The following is a description of a gene set: Human Gene Set: HP_BABINSKI_SIGN Babinski sign species: Homo sapiens Upturning of the big toe (and sometimes fanning of the other toes) in response to stimulation of the sole of the foot. If the Babinski sign is present it can indicate damage to the corticospinal tract., and this is the list of marker genes: CTDP1, PEX16, PRPH, SPTAN1, PSEN1, SDHB, SDHD, UNC13A, DARS2, BICD2, AP4M1, PLP1, POLR1A, DLAT, TSEN15, SYNE1, ABCB7, CYP27A1, MAG, C19orf12, SETX, PON1, ADAR, TPP1, PTRHD1 (NCBI Gene Id 391356), SLC44A1, UFC1 (NCBI Gene Id 51506), ERLIN2, TSEN34, NDUFS4, SPAST, PYCR2, CYP7B1, DSTYK, HNRNPA1, NDE1, MATR3, HADHB, ATP2B3, ZFR, ATXN2, ANO10, WASHC5, ARSA, HMBS (hydroxymethylbilane synthase), SPG7, CAMSAP1, CACNA1G, NUBPL, OPA1, CHCHD10, NT5C2, GPT2, CFAP410, BRAT1, RARS1, CAV1, VAMP1, FGF13, RNF170, SLC39A14, DEGS1, MDH2, ATXN3, SEPSECS, PIK3R5, SLC25A46, RFC1, MPZ, SAMD9L, PRPS1, KLC2, ETHE1, PRSS12, ITPR1, VAPB, NEK1, SOD1, SQSTM1, SLC9A7, HTT, AP4B1, FA2H, SLC16A2, MTRFR, TBC1D20 (NCBI Gene Id 170488), MORC2, GAN, COQ2, SLC33A1, POLR3A, PARS2, MFN2, UCHL1, POLR3B, MTTP, SACS, MT-TE, TIMM8A, GALC, AARS1, RUSC2, PCYT2, GRIA3, KIF5A, MCOLN1, DKK1, VPS13D, BSCL2 (NCBI Gene Id 84753), ATP6AP2, PMP22, AFG3L2, AP4S1, CHMP2B, TARDBP, KIF1C, PIGA, RNASEH1, ANG, ATXN1, SNX14, TSPOAP1, JAM2, DPM3, TSEN2, CAPN1, TREM2, PRKN, DTYMK, IBA57, COQ7, AP4E1, PDYN, TSEN54, CLDN11, IMPDH2, VRK1, KPNA3 (karyopherin subunit alpha 3), KIF1A, ATL1 (NCBI Gene Id 6681), SPART, UBAP1, ATP13A2, PRNP, SHMT2, ADPRS, FARS2, NFU1, PRICKLE1, ADGRG1, HYCC1, APOE, HSPD1, CACNA1A, SLC2A3 (NCBI Gene Id 94827), CNTNAP1, UBQLN2, EIF2S3, DDHD2, TYROBP, SPG21, NDUFA4, ZFHX3, TGM6, PFN1, DDC, RETREG1, SPG11, LYRM7, HPDL, GLT8D1, TMEM63A, MECP2, PLAA, NR4A2 (NCBI Gene Id 4929), SIGMAR1, KCNA1, GFM2, NUP54, LRP12, EEF2, ATP7A, CCT5, UGDH (UDP-glucose 6-dehydrogenase), PET117, FUS, MT-ATP6, MTPAP, PPARGC1A, TFG, GCH1, COX20, REEP1, GBA2, PI4KA (NCBI Gene Id 5297), ALDH18A1, EIF2AK2, KY, ERBB4, NFASC, LETM1, TANGO2, NUP62, PNPLA6, EARS2, DARS1 (aspartyl-tRNA synthetase 1), DAO, GFAP, TOR1A, SDHAF1, AMPD2, SLC1A4, TMEM63C, GJC2, CHP1, GJB1, ABHD16A, DDHD1, FTL, DNMT1, ASPA, CYP2U1, NIPA1, KDM5C, PIGT, AAAS, PNPT1, FXN, TRMT5, ABHD12, SLC1A2, LARGE1, HADHA, OPA3, MECR, FBXO7, MAN2B1, NDUFS1, NOP56, ARX, SNCA, AHDC1, NEFH, WWOX, IREB2, CWF19L1, B4GALNT1, ERLIN1 (NCBI Gene Id 10613), ALS2, COL4A1, LMNB1, GLE1, ZFYVE26, ABCD1, SELENOI (selenoprotein I), REEP2, SLC19A3, FBXL4, ELOVL1, PANK2, SLC2A1, TH, OPTN, DCTN1, KCNA4, ATXN7, TAF15, ATG5, VCP, PGAP1, STUB1, CPT1C, TAF2, GRID2, DNAJC3, PLA2G6, RTN2, TWNK, ERCC6 (ERCC excision repair 6, chromatin remodeling factor), POLG, AARS2, NEFL, AIFM1, CTSF, TTC19, CCNF, CNP, PON3, SDHA, GLRX5, ACOX1, HTRA1, FIG4, IRF2BPL, PON2, ATXN10 (ataxin 10), COQ4, TBK1, TTPA, PSAP, PMP2, ANXA11